Given this list of marker genes MAP2K4, PGS1, RPE, CSNK2A1, BBLN, PPA1, ASPH, GET1, ARHGEF4, SCN3A, COL4A1, GNAS, CLDN10, GRPEL1, ZW10, SAT1 (spermidine/spermine N1-acetyltransferase 1), PPP3R1, HSPA5, COX7C, ZMAT3, RPN2, MPV17, HADH, HSP90AA1, NEDD8, KIF1B, ZFR (zinc finger RNA binding protein), GTF2A2, TMOD1, ACTN1, APC, ACAD8, PDHA1, RPL14, ATP2A2, ALDH2, TUBG2, KIF5C, RIMS2, PAFAH1B1, UBP1, LAMTOR2, TAC1, CLIC2, NDUFB3, SEC31A, CAMKK2, RPL6, ROCK2, RGS20, NSFL1C, CUL2, RGS14, PCNT, PFDN2, ADGRB2, DRAP1, CACYBP, KCNIP1, PSMC2, PARP1, FAIM2, HSP90AB1, RPL38, RAPGEFL1, PANX1, LGALS8, USP6, UROS, TOP1, CCT4, B4GALNT1, TMEM147, REEP5, ROBO1, COX7A2L, FCER1G, IPO7, MXD1, CCNL1, CLIP3, WFDC1, DNAJA1, PCP4, TTC3, NDUFB8, CDK7, CDC27, PPP3CA, DIPK1A, ORC5, VAMP1, CKS2, HSPH1, ALOX5AP, PTPRR, RANBP2, DEAF1, NELL1, CCT5, ACTR1B, SST, UTP18, COPS5, TRO, FHL1, ZNF207, ATIC, DDN, SUPT7L, GNB1, CCT2, AP3S1, HLA-G, MKKS, DENND4A, OPA1, TOX3, CEPT1, MRPL15, CCT3, TFDP1, MED17, TENM1, MARS1, SEC23B, PDHX, ARCN1, PALM2AKAP2, GPR22, CRH, ECH1, MAOA, COL5A2, SLC25A6, FKBP1B, DLGAP2, MGLL, FSD1, CSNK1G3, CD59, PDIA6, PIP5K1C, TSPOAP1, GLRX, USP15, RB1CC1, MFN1, AHSA1, MGA, RSU1, EIF2B3, DDX5, ARF3, GABRB3, SNU13, MEF2A, PAK3, DNAJC8, RGS4, SDHA (NCBI Gene Id 6389), GLUL, RAD51C, EIF2B1, ELMO2, KIDINS220, here is a description of the gene set: from publication Blalock EM, Geddes JW, Chen KC, Porter NM, Markesbery WR, Landfield PW (PMID 14769913) studied in species Homo sapiens The pathogenesis of incipient Alzheimer's disease (AD) has been resistant to analysis because of the complexity of AD and the overlap of its early-stage markers with normal aging. Gene microarrays provide new tools for addressing complexity because they allow overviews of the simultaneous activity of multiple cellular pathways. However, microarray data interpretation is often hindered by low statistical power, high false positives or false negatives, and by uncertain relevance to functional endpoints. Here, we analyzed hippocampal gene expression of nine control and 22 AD subjects of varying severity on 31 separate microarrays. We then tested the correlation of each gene's expression with MiniMental Status Examination (MMSE) and neurofibrillary tangle (NFT) scores across all 31 subjects regardless of diagnosis. These well powered tests revealed a major transcriptional response comprising thousands of genes significantly correlated with AD markers. Several hundred of these genes were also correlated with AD markers across only control and incipient AD subjects (MMSE > 20). Biological process categories associated with incipient AD-correlated genes were identified statistically (ease program) and revealed up-regulation of many transcription factor/signaling genes regulating proliferation and differentiation, including tumor suppressors, oligodendrocyte growth factors, and protein kinase A modulators. In addition, up-regulation of adhesion, apoptosis, lipid metabolism, and initial inflammation processes occurred, and down-regulation of protein folding/metabolism/transport and some energy metabolism and signaling pathways took place. These findings suggest a new model of AD pathogenesis in which a genomically orchestrated up-regulation of tumor suppressor-mediated differentiation and involution processes induces the spread of pathology along myelinated axons. Genes down-regulated in patients at the incipient stage of Alzheimer's disease. Human Gene Set: BLALOCK_ALZHEIMERS_DISEASE_INCIPIENT_DN